The following is a description of a gene set: part of: DDX58/IFIH1-mediated induction of interferon-alpha/beta studied in species Homo sapiens The TRAF6/TAK1 signal activates a canonical IKK complex, resulting in the activation of NF-kappaB as well as MAPK cascades leading to the activation of AP-1. Although TRAF6/TAK1 has been implicated in Tool like receptor (TLR) mediated cytokine production, the involvement of these molecules in the regulation of type I IFN induction mediated by RIG-I (DDX58)/MDA5 (IFIH1) pathway is largely unknown. According to the study done by Yoshida et al. the DDX58:MAVS pathway requires TRAF6 and MAP3K, MEKK1 to activate NF-kappaB and MAP Kinases for optimal induction of type I IFNs. Reactome Pathway: TRAF6 mediated NF-kB activation, and this is the list of marker genes: IKBKG, MAVS, IFIH1, NFKBIA, AGER, TRAF6, TRIM4, NKIRAS2, TRAF2, RELA (NCBI Gene Id 5970), MAP3K1, S100B, TRIM25, APP (amyloid beta precursor protein), RNF135, CHUK, NFKB2, NFKBIB, NKIRAS1, IKBKB, S100A12, HMGB1, NFKB1 (nuclear factor kappa B subunit 1), RIGI, SAA1